Given this list of marker genes Anxa4, Klf4, Mapkbp1, Ssc5d, Bcl3, Ptpn22, Cactin, Elane, Map2k5, Anxa1, Bpi, Arrb1, Otud7b, Tlr6, here is a description of the gene set: studied in species Mus musculus Mouse Gene Set: GOBP_NEGATIVE_REGULATION_OF_INTERLEUKIN_8_PRODUCTION Any process that stops, prevents, or reduces the frequency, rate, or extent of interleukin-8 production.